The following is a description of a gene set: from publication Chicas A, Wang X, Zhang C, McCurrach M, Zhao Z, Mert O, Dickins RA, Narita M, Zhang M, Lowe SW (PMID 20385362) The RB protein family (RB, p107, and p130) has overlapping and compensatory functions in cell-cycle control. However, cancer-associated mutations are almost exclusively found in RB, implying that RB has a nonredundant role in tumor suppression. We demonstrate that RB preferentially associates with E2F target genes involved in DNA replication and is uniquely required to repress these genes during senescence but not other growth states. Consequently, RB loss leads to inappropriate DNA synthesis following a senescence trigger and, together with disruption of a p21-mediated cell-cycle checkpoint, enables extensive proliferation and rampant genomic instability. Our results identify a nonredundant RB effector function that may contribute to tumor suppression and reveal how loss of RB and p53 cooperate to bypass senescence. Human Gene Set: CHICAS_RB1_TARGETS_LOW_SERUM Genes up-regulated in IMR90 cells (fibroblast) grown under low serum conditions and after knockdown of RB1 by RNAi. species: Homo sapiens, and this is the list of marker genes: LMNB1, NFIB, EGFR, FMO2, MCM5, RAD51D, NIBAN1, ATOX1, NNMT, MT1H, SULF1, C4A, DTL, RNASEH2A, POLR2L, ZNF367, COX5B, CDCA7, KIR3DX1, H4C3, PTN, NDUFB2, MT2A, UQCC2, NDUFA3, RPA3, RPL36AL, MCM4, SYNE2, NICOL1, ATP5MC2, RPS21, PET100, CKLF, ATP5MF, SNHG6, SBF2-AS1, TMSB15A, ROMO1, SNRPG (small nuclear ribonucleoprotein polypeptide G), TMEM258, SLC7A14, LINC00973, ATP5MJ, SNORD60, RPL38, PCLAF (PCNA clamp associated factor), PITX1 (paired like homeodomain 1), ZNF827, INHBE, CYTOR, NDUFB4, RPL36A, CDT1, ELOB, CORIN, SNRPE, ZYX, COPS9, SYT1, NDUFA1, NSD2, CCNE2, UQCR11, MCM6, SEC62, RIF1, USP6, RAB27A, CENPW, LSM7, RNF145, SOX4, ATP5MG, ZFAS1, ATP5ME, COX6B1, MT1E, RBM39, COX7C, HELLS, WDR76, TMEM171, NDUFB1, OST4, RBIS (ribosomal biogenesis factor), MT1F, THORLNC, DEPDC1, SERPINB8, TYMS, MCM3, SNRPB, MT1X, EIF4EBP1, MTHFD2L, TOMM7, MALAT1, GDF5, NPIPB13, RPS28 (NCBI Gene Id 6234), AAK1